Given this list of marker genes AKT3, NGFR, ELK1, AKT1, NGF, PIK3CA, AKT2, PIK3CD, GRB2, SHC1, SOS1, CDKN1A, MAP2K2, RHOA, HRAS (HRas proto-oncogene, GTPase), NTRK1 (NCBI Gene Id 7825), MAP2K1, here is a description of the gene set: studied in species Homo sapiens The TrkA receptor binds nerve growth factor to activate MAP kinase pathways and promote cell growth. Human Gene Set: SA_TRKA_RECEPTOR